Given this list of marker genes ANAPC5, SKA3, SKA1, ANAPC11, CUL3, MAPK15 (mitogen-activated protein kinase 15), CDC16 (cell division cycle 16), CDC20, ESPL1, MAD1L1, MAD2L1BP, PRAP1, ANAPC7, NSMCE2, UBE2C, CDC23, DLGAP5, RB1, here is a description of the gene set: Any process that activates or increases the frequency, rate or extent of metaphase/anaphase transition of cell cycle. Human Gene Set: GOBP_POSITIVE_REGULATION_OF_METAPHASE_ANAPHASE_TRANSITION_OF_CELL_CYCLE studied in species Homo sapiens